Given this list of marker genes MGME1, MEIOB, ISG20L2, TRIR, CNOT7, XRN2, DCLRE1B (NCBI Gene Id 64858), FEN1, ENPP1, PNPT1, DDX1, EXO5, USB1, DCLRE1A, ERI3, EXOG, PAN2, CNOT8, CNOT6, PARN, DCLRE1C, REXO5, NME8, CNOT6L, PDE12, MYG1, EXOSC7, DIS3, MRE11, TOE1, TATDN1, EXO1, NME5, EXD2, POLRMT, CNOT2, POLG, RAD9A, EXOSC8, DCPS, ERI2, FAN1, DCP2, NME1, EXOSC6, ENPP2, NME7, TREX1, DIS3L2, ERI1, WRN, ENPP3, PAN3, PLD3, TREX2, EXOSC9, EXD1, APEX2, DXO, CPSF3, REXO1, RAD1, XRN1, AEN, REXO2, ZC3H12A, REXO1L1P, EXOSC4, APTX, TDP1 (NCBI Gene Id 55775), POLD1, PNLDC1, NOCT, EXOSC2, APLF (aprataxin and PNKP like factor), POLE, EXOSC1, HELZ2, REXO4, ISG20, PLD4, CNOT1, EXD3, EXOSC3, DIS3L, APEX1, RAD50, EXOSC5, EXOSC10, here is a description of the gene set: studied in species Homo sapiens Human Gene Set: GOMF_EXONUCLEASE_ACTIVITY Catalysis of the hydrolysis of ester linkages within nucleic acids by removing nucleotide residues from the 3' or 5' end.